The following is a description of a gene set: Human Gene Set: GOBP_MITOCHONDRIAL_RESPIRASOME_ASSEMBLY species: Homo sapiens The aggregation, arrangement and bonding together of respiratory enzyme complexes I, III and IV of the mitochondrial inner membrane to form a large supercomplex., and this is the list of marker genes: RAB5IF, COX7A2L, COX7A1 (cytochrome c oxidase subunit 7A1), HIGD1B, HIGD2A, COX7A2, HIGD2B, HIGD1C, COX7A2P2 (NCBI Gene Id 345363), HIGD1A, STMP1